The following is a description of a gene set: A protein complex that catalyzes the ligation of cleaved pre-tRNAs by directly joining spliced tRNA halves to mature-sized tRNAs by incorporating the precursor-derived splice junction phosphate into the mature tRNA as a canonical 3',5'-phosphodiester. Human Gene Set: GOCC_TRNA_SPLICING_LIGASE_COMPLEX studied in species Homo sapiens, and this is the list of marker genes: C2orf49, RTCB, FAM98A, ZBTB8OS (zinc finger and BTB domain containing 8 opposite strand), DDX1, FAM98C, RTRAF, FAM98B